The following is a description of a gene set: from publication Cipolletta D, Feuerer M, Li A, Kamei N, Lee J, Shoelson SE, Benoist C, Mathis D (PMID 22722857) species: Homo sapiens We identified Pparg as a major orchestrator of the phenotype of adipose-tissue resident regulatory T cells (VAT Tregs). To explore the contribution of Pparg1 and 2 in the generation of the VAT Tregs-specific gene signatures, CD4+FoxP3- T cells were transduced with Foxp3+/- Pparg1 (or Pparg2), treated with Pioglitazone or vehicle, and double sorted for microarray analysis. Genes up-regulated in CD4 over-expressing: FOXP3 and PPARg2 form of PPARG versus FOXP3. Human Gene Set: GSE37533_PPARG2_FOXP3_VS_FOXP3_TRANSDUCED_CD4_TCELL_UP, and this is the list of marker genes: ZFP64, MYH7, MICAL2, ATRN, ZMAT3, SNX4, SNRPD1, SLC25A36, TRIM46, RMND1, CEP83, PFN2, ZFAND5, PABPC4, ARRB1, USP12, CUL3, MSR1, COA1, FASTKD1, ARHGDIB, DNAJB1, NDUFA2, POGLUT2, KCNH2, TDP1, B4GALT6, LYN, MLLT11, HOXA11, SQLE, LRRC8D, BSDC1, CNN2, RAN, PLIN2, ITGAE, GPER1, ARB2A, NPM3, PIK3CB, TOPBP1, ARL6IP5, CDC42EP3, SEPHS1, DLG3, GPATCH3, SEPTIN8, RBM38, PRPF38B, GALNT10, PIM1, GIT2, SIK2, NANS, STX6, AHR, BLCAP, UBE4B, SPTB, DKC1 (NCBI Gene Id 1736), MOAP1, HNRNPA0 (heterogeneous nuclear ribonucleoprotein A0), CCT4, HILPDA, RNF44, DDX28, PSMD10, APEX1, SMUG1, WASF3, ACO1, NDUFB2, GALNT11, CCT3, ZFP37, SRPK1, AKR1B10, RIT1, BDH1, TCP1, CPB1, INTS8, HSPA4L, NT5DC2, DDX50, MAPK12, ATG4A, CARHSP1, SNX13, NINL, USP22, EEF1E1, BRCC3, PITPNM1, SEC24C, GET1, HIF3A, GLOD4, ZNF331, CYP2A7P1, DNAAF2, WRNIP1, RPP40, MOSPD1, NDUFA1, PHF10, CLK4, POLB, TMEM262, UTP25, CERK, PKIA, FARSA, MRTFB, NME1, NEFM, ZBTB17, CCNF, LDHB, RRS1, GSR, IL11, ZNF551, MAGEF1, METTL9, ASAP2, BMP6, DHX32, ATP5MC1, RMND5A, SUPV3L1, PRCC, PDXDC1, ZFTA, WIPI2, CYREN, KDM1A, BICD2, WDR91, FAIM, DOLK, SNN, CROT, URI1, CENPS, TPT1P8, ANXA2P3, PITPNA, CXADR, CD93, ADGRG1, ZNF230, WDR12, KIR2DL3, PRKACB, TRAF2 (NCBI Gene Id 7186), MAEA (macrophage erythroblast attacher, E3 ubiquitin ligase), PAGR1, VIP (vasoactive intestinal peptide), SAMSN1, TRIM37, FRG1, SKP2, NACA2, TIAM2, TJP2, MCCC1, PHF20, TFDP1, RAD51C, POLQ, MORC2, THEM6, AMPD2, MXD3, TRAK2, PCDH11Y, MDH2, NOX4 (NCBI Gene Id 50507), FAM98A, FAM200C, CLNS1A (NCBI Gene Id 1207), HMG20A, ADGRA3, ABHD10, COTL1, UROD, MN1, REPIN1, RGS2, PIDD1, TTC3, ZFAND1, SPRY2, POLR3K, TSPAN6, IER3, CAPN7, MAPK14